Given this list of marker genes RBM24, LARP4B, ELAVL4, ARID5A, TENT4A, TENT4B, here is a description of the gene set: Any process that activates or increases the frequency, rate or extent of 3'-UTR-mediated mRNA stabilization. studied in species Homo sapiens Human Gene Set: GOBP_POSITIVE_REGULATION_OF_3_UTR_MEDIATED_MRNA_STABILIZATION